The following is a description of a gene set: Mouse Gene Set: GOMF_INTRACELLULARLY_CAMP_ACTIVATED_CATION_CHANNEL_ACTIVITY Enables the transmembrane transfer of a cation by a channel that opens when intracellular cAMP has been bound by the channel complex or one of its constituent parts. species: Mus musculus, and this is the list of marker genes: Hcn3, Cnga1, Cnga2, Hcn2, Cnga3, Hcn1, Cnga4, Cngb1, Hcn4, Cngb3